The following is a description of a gene set: Cytokines mediate cell-cell communication in the immune system and represent important therapeutic targets. A myriad of studies have highlighted their central role in immune function, yet we lack a global view of the cellular responses of each immune cell type to each cytokine. To address this gap, the authors created the Immune Dictionary, a compendium of single-cell transcriptomic profiles of more than 17 immune cell types in response to each of 86 cytokines (>1,400 cytokine-cell type combinations) in mouse lymph nodes in vivo. A cytokine-centric view of the dictionary revealed that most cytokines induce highly cell-type-specific responses. For example, the inflammatory cytokine interleukin-1β induces distinct gene programmes in almost every cell type. A cell-type-centric view of the dictionary identified more than 66 cytokine-driven cellular polarization states across immune cell types, including previously uncharacterized states such as an interleukin-18-induced polyfunctional natural killer cell state. Genes positively differentially expressed in cell type: pDC (plasmacytoid dendritic cell) upon treatment with cytokine: IL-10 in mouse lymph nodes in vivo. Mouse Gene Set: CUI_PDC_IL10_RESPONSE_UP species: Mus musculus from publication Cui A, Huang T, Li S, Ma A, Pérez JL, Sander C, Keskin DB, Wu CJ, Fraenkel E, Hacohen N (PMID 38057668), and this is the list of marker genes: Pdia3, Msmo1 (methylsterol monoxygenase 1), Rftn1, Sp110, Bcl11a, Prdx1, Wfdc17, Dhcr24, Kdr, Napsa, Cfl1, Ly6a, Srsf2 (NCBI Gene Id 28128), Rrbp1, Tspo, Csf2rb, Atp2b4, Hnrnpa2b1, Cox5a, Ell2, Bcl3, Calr, Hspd1, Reep5, Hspa8, Actr2, Cd7, Smdt1, Tapbp, Pltp, Hmgcs1, Rnase6, Hsp90ab1, Pou2f2, Ly86, Ldlr, Cfp, Cd38, Gpx4, Skap2, Pfn1, Csf2rb2, Psme2, Rap1a, Cyp51, Dynll1, Ptpn1, Ctsh, Plac8, Sub1, Ubxn4, Sqle, Calm1, Slpi, Cd82, Stat3, Idi1, Nme1, Timm10b, Fcer1g, H2-T23, Fdps, Glipr1, Ptprc, Il7r, Vwa5a, Hsp90b1, Ifi207